Given this list of marker genes Lfng, Bcl6, Dpp4, Il2rg (interleukin 2 receptor, gamma chain), Spi1, Dock11, Enpp1, Ada, Lilrb4a, Irf8, Il10, Lgals1, Phf14, Plcg2, Dll1, Nkx2-3, Itfg2 (integrin alpha FG-GAP repeat containing 2), Ptk2b, Bcl3, Cmtm7, St3gal1, Il6, Pou2f2, Ddrgk1, Tnfaip3, Plcl2, Mfng, Lgals8, Dock10, Notch2, Il2, 6030468B19Rik, Slamf8, Nfkbiz, Cd19, Il21, Muc19, Xbp1, Itm2a, Nfatc1, Malt1, Cdh17, Rag2, Pou2af1, Gpr183, here is a description of the gene set: species: Mus musculus Mouse Gene Set: GOBP_MATURE_B_CELL_DIFFERENTIATION The process in which transitional stage B cells acquire the specialized features of mature B cells in the spleen.